The following is a description of a gene set: The series of molecular signals that conveys information from the endoplasmic reticulum to the nucleus, usually resulting in a change in transcriptional regulation. species: Mus musculus Mouse Gene Set: GOBP_ER_NUCLEUS_SIGNALING_PATHWAY, and this is the list of marker genes: Insig2, Eif2s1, Ptpn1, Nck1, Nck2, Akt3, Arhgef10l, Spring1, Selenos, Atg10, Erlin1, Insig1, Atp2a2, Atf4, Igtp, Amfr, Atf6, Ccdc47, Tmco1, Ppp1r15b, Agr2, Tmem33, Nfe2l2, Tmed2, Rpap2, Bid, Trp53, Ddit3, Srebf2, Srebf1, Qrich1, Ddrgk1, Akt2, Manf, Erlin2, Akt1, Abca7, Gsk3b, Atad3a, Ins2, Wfs1, Zbtb7b, Scap, Bcl2l11, Ptpn2, Eif2a, Eif2ak3, Paqr3, Bok, Hspa5 (NCBI Gene Id 99198), Atf6b